Given this list of marker genes TOPBP1, UGT1A10, CCND1, ST6GAL1, RGS16, MRPL18, PHLDA1, KCNN4, RASA1, HPRT1, TUBB6, SEPHS2, H2AX, SNU13, CENPA, ZWINT, PCLAF, TOP1 (DNA topoisomerase I), FAM3C, CTSB, RBL1, PLSCR1, GTF2A2, SLC6A8, IGF2R, RRM1, CRABP1, TOP2A, PLPP3, FUT8, CRISP3, RAD51, CASK, GDNF, NAP1L1, PPID, TCF12, ANGPTL2, POLA1, CENPV, RFC5, CCL2, NFE2L2, LUM, ADAM19, GREM2, EVI2A, CKS1B, SSRP1, ERGIC3, HMGB3, CYTIP (NCBI Gene Id 9595), TNFAIP2, HAS2, IVNS1ABP, E2F8, SPP1, THBS2, MARCKSL1, SPTSSA, MYEF2, AHCY, MAPK6, PLK4 (polo like kinase 4), FDX1, SEMA7A, BZW2, PCNA, AURKA, PCDH7, GJA1, UHRF1, SLBP, CXorf38 (NCBI Gene Id 159013), ANP32E, EFNB2, SET, MYO1B, MED10, HMGA2, TMSB4X, TPBG, HAUS3, TIMP1, ANKH, SYCP3, RANGAP1, BNC1, SPRED2, PRKCB, LSM8, TIPARP, CTSV, IL1RL1, RBM3, SLC12A2, APBB1IP, ETV4, EVL (Enah/Vasp-like), HNRNPD, SMS, NFKBIA, NCAM1, UBA2, PSMA3 (proteasome 20S subunit alpha 3), NGEF, ITGA6, VCAM1, SMC2, ERH, APCDD1, FIGNL1, NCAPH, ILF2, RRM2, CASP4, DNMT1, CDC7, BACH1, ITGB7, AREG (NCBI Gene Id 727738), NAV2, TGFB1, EREG, DLK1, NOCT, UBE2D2, HMGN2, DHX9, PDPN, here is a description of the gene set: Human Gene Set: CHIARADONNA_NEOPLASTIC_TRANSFORMATION_KRAS_UP Mutational activation of ras genes is required for the onset and maintenance of different malignancies. Here we show, using a combination of molecular physiology, nutritional perturbations and transcriptional profiling, that full penetrance of phenotypes related to oncogenic Ras activation, including the shift of carbon metabolism towards fermentation and upregulation of key cell cycle regulators, is dependent upon glucose availability. These responses are induced by Ras activation, being specifically reverted by downregulation of the Ras pathway obtained through the expression of a dominant-negative Ras-specific guanine nucleotide exchange protein. Our data allow to link directly to ras activation the alteration in energy metabolism of cancer cells, their fragility towards glucose shortage and ensuing apoptotic death. studied in species Mus musculus from publication Chiaradonna F, Sacco E, Manzoni R, Giorgio M, Vanoni M, Alberghina L (PMID 16607279) Genes up-regulated in transformed NIH3T3 cells (fibroblasts transformed by activated KRAS) vs normal cells.